Given this list of marker genes WDR38, AGMAT (agmatinase (putative)), TSSK3, OR10AD1, SEZ6L, AK5, GRHL3, IRF7, SYNDIG1L, RIMS4, TNFRSF11B, CCL24, KRT26, FOXL2, NME8, CALHM5, UBTFL1, LECT2, LRCH4, ABCB7, TENT4A, NECTIN3, TBPL1, MYO1A, UBL4A, KRT2, GCM1, LRRC3, NXPH3, IBA57, GET4, PDZK1IP1, COL2A1 (NCBI Gene Id 444981), KRTAP4-11 (keratin associated protein 4-11), TMEM60, METAP2, HAS1, ADHFE1, CACNA1D, SMPD5, TAGLN3, WHRN, ZDHHC5, FBXO16, ST3GAL4, ZNF473, DAGLA, ZWILCH, GOLT1A, HSPA4L, AKAP6, HIRA, TRIM59, MRPS18C (NCBI Gene Id 51023), KCNE5, ECHDC2, PPP1CB, MUC4, SBSPON, TRMT12, PHETA2, UNCX, UBE2T, LTA, GHRHR, GSX2, RNF11, UPP2, AHSG, RGS16, LLGL1, PDE11A, HRG, ACSS1, SMAD9, ENPP3, RAP1A, TRAPPC6B, CARS1, ADORA1, KLF13, CTCF, SLAMF9, FXYD7, TMEM132C, NPHS2, DNAAF1 (dynein axonemal assembly factor 1), SMIM1, ZIM2, PRIM1, TTLL11, PLPPR1, MYEF2, E2F8, CIT, SPTSSB, DBH, SNAI3-AS1, LINC01160, ZMAT2, SLC16A6, PCK2, SPAG16, ZNF428, YBEY, SPMIP9, LSM12, BIK, ABCB4, MYL4, MMRN2, CYP4F22, PBK, APOBEC2, PTPN20, COL6A3, CFHR1, ARHGAP19, MSS51, SELE (selectin E), C4BPB, OMP, SNX11, GAL3ST4, IL13RA1, PANK2, STRADB, FAM222A, CEND1, SLC13A5, TAAR1, CRIP3, FKBP6, SP7, CITED4, SAXO4, TNFRSF10A, KEL, TNFRSF9, ACKR2, SHC1, ZPBP2 (zona pellucida binding protein 2), CUZD1, AMIGO1, PAMR1, KIF12, RBMXL2, FBXO43, RMDN3, LBX1, IGF2R, AIFM2, R3HCC1L, TENM4, ZNF750, AMER3, CRISP2, DGKQ, ANKRD54, SLAMF6, GGNBP2, CA2, TIPIN, FABP12, CHRD, SEBOX, GLRX5, KCND2, NFASC, SLCO1C1, TMEM138, ZFR2, CELA2A (NCBI Gene Id 63036), MPP3, H2AX, GSDMC, EPM2A, TYMS, EMILIN2, UROC1, TMEM200C, LTF, NOTUM, SLC29A1, CDC20B, PEDS1, DRC3, FANCD2, LGI3, DCAF12, FBLN1, IL21, NR2F2, PIK3R3, RAB26, PLCH2, PI4K2B, COX17, MLST8, ADAMTS9, here is a description of the gene set: Genes down-regulated in comparison of LSK versus erythroblasts. from publication Konuma T, Nakamura S, Miyagi S, Negishi M, Chiba T, Oguro H, Yuan J, Mochizuki-Kashio M, Ichikawa H, Miyoshi H, Vidal M, Iwama A (PMID 21540074) Human Gene Set: GSE27786_LSK_VS_ERYTHROBLAST_DN Each fraction of mouse hematopoietic cells was purified by cell sorting from bone marrow of 8-week-old C57BL/6 mice, and its gene expression was analyzed. species: Homo sapiens